The following is a description of a gene set: from publication Nikolsky Y, Sviridov E, Yao J, Dosymbekov D, Ustyansky V, Kaznacheev V, Dezso Z, Mulvey L, Macconaill LE, Winckler W, Serebryiskaya T, Nikolskaya T, Polyak K (PMID 19010930) A single cancer cell contains large numbers of genetic alterations that in combination create the malignant phenotype. However, whether amplified and mutated genes form functional and physical interaction networks that could explain the selection for cells with combined alterations is unknown. To investigate this issue, we characterized copy number alterations in 191 breast tumors using dense single nucleotide polymorphism arrays and identified genes with copy number gain organized into 30 amplicons. Amplicons were distributed unequally throughout the genome. Each amplicon had distinct enrichment pattern in pathways, networks, and molecular functions, but genes within individual amplicons did not form coherent functional units. Genes in amplicons included all major tumorigenic pathways and were highly enriched in breast cancer-causative genes. In contrast, genes with somatic mutations in breast cancer were distributed randomly over the genome, did not represent a functionally cohesive gene set, and were relatively less enriched in breast cancer marker genes. Mutated and gained genes did not show statistically significant overlap but were highly synergistic in populating key tumorigenic pathways including transforming growth factor beta, WNT, fibroblast growth factor, and PIP3 signaling. In general, mutated genes were more frequently upstream of gained genes in transcription regulation signaling than vice versa, suggesting that mutated genes are mainly regulators, whereas gained genes are mostly regulated. ESR1 was the major transcription factor regulating amplified but not mutated genes. Our results support the hypothesis that multiple genetic events, including copy number gains and somatic mutations, are necessary for establishing the malignant cell phenotype. studied in species Homo sapiens Genes within amplicon 21q22 identified in a copy alterations study of 191 breast tumor samples. Human Gene Set: NIKOLSKY_BREAST_CANCER_21Q22_AMPLICON, and this is the list of marker genes: COL18A1, FTCD, POFUT2, C21orf58, YBEY, ADARB1, PCNT, COL6A2 (collagen type VI alpha 2 chain), DIP2A, COL6A1, LSS, SPATC1L, SLC19A1, MCM3AP, PCBP3, COL18A1-AS1 (NCBI Gene Id 378832)